Given this list of marker genes Kifc2 (kinesin family member C2), Erf, Igdcc3, Ntsr1, Cryba4, Eps8l3, Entpd6, Mapre3, Tnfsf14, Tmem250, Scnn1b, Akap1, Pou2af3, Mllt6, Syndig1l, Sox13, Tbx2, Trim3, Ccnd3, Sema6a, Gng2, Stra6l, Apod, Meis2, Msn, Diras1, Vsnl1, Tnfrsf11a (NCBI Gene Id 21934), Stxbp1, Slc7a1, Scara3, Tmem132b, Nsd1, Hps1, Sema4g, R3hdm2, Hadh, Sorcs2, Ptp4a1, Cyp26b1, Smad9, Reep5, Elavl4, Dip2b, Slc25a23, Hoxc13, Mgat3, Rexo1, 4931414P19Rik, Dnajb5, Adm2, Ascl1, Deptor, Zfp36l1, Csdc2, Asb13, 4930571K23Rik, here is a description of the gene set: studied in species Mus musculus from publication Chen Y, Wang X (PMID 31504780) Mouse Gene Set: MIR_12192_5P Genes predicted to be targets of miRBase v22 microRNA mmu_miR_12192_5p in miRDB v6.0 with MirTarget v4 prediction scores > 80 (high confidence targets).